The following is a description of a gene set: Human Gene Set: KAECH_NAIVE_VS_DAY8_EFF_CD8_TCELL_DN species: Homo sapiens from publication Kaech SM, Hemby S, Kersh E, Ahmed R (PMID 12526810) How and when memory T cells form during an immune response are long-standing questions. To better understand memory CD8 T cell development, a time course of gene expression and functional changes in antigen-specific T cells during viral infection was evaluated. The expression of many genes continued to change after viral clearance in accordance with changes in CD8 T cell functional properties. Even though memory cell precursors were present at the peak of the immune response, these cells did not display hallmark functional traits of memory T cells. However, these cells gradually acquired the memory cell qualities of self-renewal and rapid recall to antigen suggesting the model that antigen-specific CD8 T cells progressively differentiate into memory cells following viral infection. Genes down-regulated in naïve CD8 T cells compared to effector CD8 T cells at the peak expansion phase (day 8 after LCMV-Armstrong infection)., and this is the list of marker genes: NUSAP1, CDC25C, S100A10, SERPINB9, ETFB, ADAM19, GNPDA1, BHLHE40, MRPL27, ENSG00000286190, PTGR1, REEP5, BATF, HLA-A, ERRFI1, KIF2C, SLC2A3, GALNT3, LMAN2, KLRC1, CKS1B, CDC34, GZMB, SGO1, YBX3, DHRS1, TYMS, MAPRE2, KRTCAP2, TACC3, LAMC1, BBLN, STMN1, ITGB1, PFKP, LGALS1, IL18RAP, ID2, AK3, IL18R1, BTF3, TSPAN31, H2AZ1, GGH, ANXA6, TCF19, CHD7, TNFRSF1B, AHNAK, UNC119B, PGLYRP1, KLRK1, RACGAP1 (NCBI Gene Id 94651), CTLA4, KCTD9, ITGAX, PRC1, MKI67, MYO1F, CARHSP1, CDKN3, ROM1, CD48, CDKN2C, MED12L, CST7, LGALS3, MAP7D1, ANXA2, RPA2, RNPEP, MNS1, RSU1, CD160, SEC61G, ARF6, SH2D1A (SH2 domain containing 1A), DNAJC1, GZMK, ACOT7, DSTN, PLP2, MBD2, DLGAP5, RRM2, CASP1, NUCB1, CRIP2, DCPS, ECH1, NDUFB7, PTPN13, CAPZB, F2RL3, PTTG1, MRPL20, TXNDC5, GLRX, F2R, ADPRH, TXN (NCBI Gene Id 7295), CDK1, SEPTIN10, BAG1, NRP1, DENND5A, CDK2AP1, PRRC1, SH2D2A, DOCK5, PSMD8, FASLG, BAK1, S100A11, PSMA2, CDCA5, RHOQ, KIF22, PRF1, KLRG1, TOP2A, CAPNS1, PLSCR1, CRIP1, BCL2A1, BIRC5, S100A6, AP2S1, EMP1, SNRNP27, RORA, CXCR3, CHPT1, RRBP1, CCR5, GABARAPL2, LAMTOR5, ACYP2, ABRACL, NCAPH, LXN, S100A13, PERP, CCDC12, CLIC4, E2F8, GEM, PRDM1, ANXA1, CD44, ITGA4, VPS29, CASP4, SNX10, PRR13, UBE2J2, HK2, HASPIN, ADAM8, FRG1, CCL5, TRAPPC1, HOPX, EFHD2, NDUFB9, CCR2, HMGB2, CASP7, ACTB, IFNG, UBL5, NDUFV3, SLC66A3, ATP6V0E1, GZMA, CDC20, ARL6, LITAF, SRP14, LGALSL, SMAP1, ATP5MF (ATP synthase membrane subunit f), REPS1, DBI, NDUFV2, PRDX4, PRUNE1 (prune exopolyphosphatase 1), FAM89B, PRELID1, KIF11, IFITM10, LIG1, TBCB, COX17, DNAJC15, IDE, PRDX1, CCNB2, S100A4, MDFIC